The following is a description of a gene set: Genes predicted to be targets of miRBase v22 microRNA hsa-miR-4999-5p in miRDB v6.0 with MirTarget v4 prediction scores > 80 (high confidence targets). studied in species Homo sapiens from publication Chen Y, Wang X (PMID 31504780) Human Gene Set: MIR4999_5P, and this is the list of marker genes: ENOSF1, CCNL2, TSPY3, QDPR, CA13, CEP44, LMX1A, GLCE, TWNK, TSPY4, KIAA1549, TSPY1, NEGR1, CTSS, SLMAP, BMP6, ZNF143 (zinc finger protein 143), ADAMTS5, BRINP3, ARL8B, IL1R1 (NCBI Gene Id 3554), RUNX1T1, SHC4, FOXP2 (forkhead box P2), TOMM40L, TM2D3, DCX, SLC38A2, TBC1D9, AIDA, PPP1R16B, TSPY8, GTF2A2, SREK1, FSD1L (NCBI Gene Id 83856), RO60, CNTNAP2, EAF2, TMEM117, SFTPA1, SESN1, CAMK4, DMAC1, TMEM196, FAM8A1, PHF12, LFNG, TSPY10, MED21, EIF4ENIF1, KDM5B, SMAD6, TMEM156 (NCBI Gene Id 80008), SEC62, R3HDM1, CLPX, ARL5B, PIH1D2, EIF4E, MSX2, NRG1, CAT, CAMTA1, NCAM1, TSPY2, OTX1, ZBTB43, CD40LG, CLXN, PDK3, FAM83A, ELOVL5, SDHB, MYBL1, OTUD4, SMARCA4, ANKRD12, USP25, FAM76B, WDFY3, RAP2C, GABRA1, HECW2 (NCBI Gene Id 57520), KLLN, USP42, SCD5, CTNNB1, ZFAND5, UBE2F, LAYN, DYNLT3, PDGFRB, RHOU, PALS2, KRT14, DYRK2, TEX55, GEMIN8, APOL3, TLR7